Given this list of marker genes Skil, Nacc2, Fbh1, Pias4, Trp73, Rad9a (NCBI Gene Id 19367), Mtch2, Rps3, Plscr1, Steap3, Rpl26, Knl1, here is a description of the gene set: Any process that activates or increases the frequency, rate or extent of intrinsic apoptotic signaling pathway in response to DNA damage. studied in species Mus musculus Mouse Gene Set: GOBP_POSITIVE_REGULATION_OF_INTRINSIC_APOPTOTIC_SIGNALING_PATHWAY_IN_RESPONSE_TO_DNA_DAMAGE